Given this list of marker genes SELENON, GABRG2, ATP1A2, NDE1, GDF3, COL2A1, PTPN22, TLR3, NEK9, TRAF3, SCN1B, PCDH19, MYL11, GDF6, FHL1, FAS, TICAM1, UNC93B1, DKK1, MYH3, SCN2A, GABRA1, SCN9A, MYH7, LMNA, NDUFS3, IRF3, NOG, SCN1A, MEOX1, CACNA1A, TTN, PRRT2, TBK1, ACVR1, ERLIN2, COL6A2, here is a description of the gene set: Limitation of neck motion species: Homo sapiens Human Gene Set: HP_LIMITATION_OF_NECK_MOTION